The following is a description of a gene set: studied in species Homo sapiens Genes down-regulated in hairy cell leukemia (HCL) compared with normal and other neoplastic B cell populations. Human Gene Set: BASSO_HAIRY_CELL_LEUKEMIA_DN from publication Basso K, Liso A, Tiacci E, Benedetti R, Pulsoni A, Foa R, Di Raimondo F, Ambrosetti A, Califano A, Klein U, Dalla Favera R, Falini B (PMID 14707115) Hairy cell leukemia (HCL) is a chronic B cell malignancy characterized by the diffuse infiltration of bone marrow and spleen by cells displaying a typical hairy morphology. However, the nature of the HCL phenotype and its relationship to normal B cells and to other lymphoma subtypes remains unclear. Using gene expression profiling, we show here that HCL displays a homogeneous pattern of gene expression, which is clearly distinct from that of other B cell non-Hodgkin lymphomas. Comparison with the gene expression profiles of purified normal B cell subpopulations, including germinal center (GC), pre-GC (naive), and post-GC (memory) B cells, shows that HCL cells are more related to memory cells, suggesting a derivation from this B cell population. Notably, when compared with memory cells, HCL cells displayed a remarkable conservation in proliferation, apoptosis, and DNA metabolism programs, whereas they appeared significantly altered in the expression of genes controlling cell adhesion and response to chemokines. Finally, these analyses have identified several genes that are specifically expressed in HCL and whose expression was confirmed at the protein level by immunocytochemical analysis of primary HCL cases. These results have biological implications relevant to the pathogenesis of this malignancy as well as clinical implications for its diagnosis and therapy., and this is the list of marker genes: PAWR, CXCR5, TRAF5, IGHV5-78, TNFAIP8, TMEM131L